The following is a description of a gene set: The infant leukemia-associated gene Ott1 (Rbm15) has broad regulatory effects within murine hematopoiesis. However, germ line Ott1 deletion results in fetal demise prior to embryonic day 10.5, indicating additional developmental requirements for Ott1. The spen gene family, to which Ott1 belongs, has a transcriptional activation/repression domain and RNA recognition motifs and has a significant role in the development of the head and thorax in Drosophila melanogaster. Early Ott1-deficient embryos show growth retardation and incomplete closure of the notochord. Further analysis demonstrated placental defects in the spongiotrophoblast and syncytiotrophoblast layers, resulting in an arrest of vascular branching morphogenesis. The rescue of the placental defect using a conditional allele with a trophoblast-sparing cre transgene allowed embryos to form a normal placenta and survive gestation. This outcome showed that the process of vascular branching morphogenesis in Ott1-deficient animals was regulated by the trophoblast compartment rather than the fetal vasculature. Mice surviving to term manifested hyposplenia and abnormal cardiac development. Analysis of global gene expression of Ott1-deficient embryonic hearts showed an enrichment of hypoxia-related genes and a significant alteration of several candidate genes critical for cardiac development. Thus, Ott1-dependent pathways, in addition to being implicated in leukemogenesis, may also be important for the pathogenesis of placental insufficiency and cardiac malformations. Mouse Gene Set: RAFFEL_VEGFA_TARGETS_UP species: Mus musculus Genes up-regulated in hearts of E18.5 embryos upon knockout of VEGFA. from publication Raffel GD, Chu GC, Jesneck JL, Cullen DE, Bronson RT, Bernard OA, Gilliland DG (PMID 18981216), and this is the list of marker genes: Pbx1, E2f3, Sox11, Hey2, Acvr2b, Wt1, Gnb1l, Hif1a, Cited2